Given this list of marker genes Nup107, Pdzd11, P2rx7, Plekha7, Nup205, Gsdmd, Atp5mc3, Tpr, Tspan33, Bad, Adam10, Atp1a3, Tmem170, Nup98, Rtn4, Atp5mc2, Afdn, Fxr1, Ahctf1, Nup153, Nup93, Ndc1 (NCBI Gene Id 72787), Ano6, here is a description of the gene set: species: Mus musculus Mouse Gene Set: GOBP_PORE_COMPLEX_ASSEMBLY The aggregation, arrangement and bonding together of a set of components to form a pore complex. A pore complex is a small opening in a membrane that allows the passage of liquids and/or gases.